Given this list of marker genes ME1, TNFRSF1B, ANKRD36BP2, EGOT, TRIP10, RXRB (retinoid X receptor beta), ALOX5, INPP5E, KRT5, ADAMTS6, OSBPL8, STYXL1, SIRPA, GET1, PRKAR2B (NCBI Gene Id 5577), ITGAE, RITA1, MAN1A2, CNOT7, CMC4, RHD, MYL4, PTEN, MTIF2, RAB38, SLITRK2, DUSP6, ECE2, LRRC59, RNF125, MTM1, VTI1B, DAO, TRAK2 (trafficking kinesin protein 2), OXR1, NME7, IMPDH1, COLQ, MC3R, ATG14, DIDO1, MAGOH2P, STS, ARL6IP5, RNFT2, ZBTB14 (zinc finger and BTB domain containing 14), DOP1A, AHNAK, TBX6, CCNK, GMFB, DUOX2, BMPR1A (NCBI Gene Id 8035), HNRNPA0, OLA1, PRKAR2A (NCBI Gene Id 5576), RAB5B, IKZF5, PMF1, GAP43, LMCD1 (NCBI Gene Id 29995), HK1, JRKL (NCBI Gene Id 8690), ACO1, RFK, AP1M2, AMZ2, RAB33A, EIF2B1 (NCBI Gene Id 1967), TMEM260, RAB22A, RIOK3, MGAT4B, TTC19, ECHDC3, SPRY4, CEP15, ANKRD26, IGBP1, TENT5C, FSTL4 (follistatin like 4), EGR2, SRP19, NMRK2, NIPAL2, KIF2C, NF1, NACC2, TMEM126B, EIF2S2, EIF4B, AFDN, GPS1, HLTF, ENC1, GKN1, NT5DC2, SH3GL3, SCAF4, CNOT8, MCUB, SNX13 (NCBI Gene Id 23161), SEPTIN2, BMPR1B, MSANTD2, SST, PSG3, DNASE1L2, GPR135, FRK, PWAR5, DSCC1, CLK4, CERK, GABPB1, ASAH1, ZKSCAN3, KIAA0586, NELFCD, LY86, ODC1, PIGH, OVOL3, PEAK1, TMF1, GSK3B, SPATA1, GABBR1, POP5, ST13, TBC1D5, IARS2, TOM1L1, MAGEA8, CRADD, RPL11, PLXNA2, MOCS2, ZNF230, GPR31 (NCBI Gene Id 2853), SLC35E2B, LRRC8D, ABHD11, PDLIM3, DCAF6, UNC119, ACP1, AGBL5, PPP3CA, CYP2A7P1, SENP2, TYRO3, DENND2A, GMPR2, PLAC8, VEZF1, ADGRV1, CRBN, PABPC4, SLC35C1, MARCHF5, STATH, KMT5B, MYO1F, TEAD1, AUNIP, SALL2, CD8B, TNFRSF10D, MCUR1, AP4E1, BBS9, ABHD4, IFT46, AVEN, MBP, DHX40, CNR2, PEX2, DIAPH2, IFRD2, CPE, GUCY1B2, TMX4, CYBRD1, GOLGA2, CYP4A11, GTF2H1, PLXNA3, LSM7, RAPGEF3, ATG5, ING2, CLEC1B (NCBI Gene Id 51266), BTNL8, JAK1, here is a description of the gene set: Genes up-regulated in T reg: peripheral lymph nodes versus thymic CD24 low. We investigated at which stage of maturation commitment to a stable Foxp3-expressing phenotype takes place. We assessed stability of Foxp3 expression in thymic Foxp3+ Treg subsets of different maturity, defined by CD24 expression. Next we compared gene expression profiles of Foxp3+ Treg subsets (+) of different maturity (24lo, 24int, 24hi) and could identify a set of genes that were specifically up or downregulated in Foxp3+ Tregs, but not in Foxp3- conventional T cells, in a maturation-dependent manner. from publication Toker A, Engelbert D, Garg G, Polansky JK, Floess S, Miyao T, Baron U, Düber S, Geffers R, Giehr P, Schallenberg S, Kretschmer K, Olek S, Walter J, Weiss S, Hori S, Hamann A, Huehn J (PMID 23420886) Human Gene Set: GSE42021_TREG_PLN_VS_CD24LO_TREG_THYMUS_UP studied in species Homo sapiens